The following is a description of a gene set: Mouse Gene Set: GOMF_BRANCHED_CHAIN_AMINO_ACID_TRANSMEMBRANE_TRANSPORTER_ACTIVITY Enables the transfer of branched-chain amino acids from one side of a membrane to the other. Branched-chain amino acids are amino acids with a branched carbon skeleton without rings. species: Mus musculus, and this is the list of marker genes: Slc43a2, Slc25a44, Slc7a5, Slc6a15, Slc7a8, Slc3a2, Slc38a9, Slc43a1, Slc6a14